Given this list of marker genes Rnf130, Pnisr, Tut4 (terminal uridylyl transferase 4), Rnf150, Tsc22d3, Nop53, Per1, Aph1c, Ssh2, Egr1, Rin2, Gpx1, Pdcd4, Hspa1a, Sult1a1, Il13ra1, Gfra2, Il1b, Brd3, Tent5a, Pold4, Eif3h, Trappc5, Ccdc88a, Sirpb1c, Creg1, Bmyc, Klhl24, Cd48 (CD48 antigen), Il6ra, Stap1, Slc38a9, Stk17b, Dhrs3, Ccl6, Ier2, Fyb1 (FYN binding protein 1), Tnfaip8, Abcc1, Nsa2, Clec4a1, Slc38a1, Nadk, Eef1d, Clec4b1, Npm1, Kctd12 (NCBI Gene Id 239217), Paip2, B4galt6, Slc43a2, Ltb, Mapk14, Rin3 (NCBI Gene Id 97835), Fosb, Rsf1, Klf2, Sla, Ypel3, Macf1, Ing1, Rsrp1, Gdi2, Arhgap9, Dusp1, Ccl9, Ramp1, Jmjd1c, Pmaip1, Cd244a, Niban1, Eef1b2, Prcp, Mcemp1, Tmem50a, Asap1, Dab2, St8sia4, Smpdl3a, Igsf6, Akap13, Hlx, Fth1, Cyp4f16, Ank, Flt3, Cd33, Cnpy2, Nr4a1, Ckb, Clec4a2, Mxd4, Smad7, Arhgap45, Eif3f, Rgs10, Foxp1, Higd2a, Eef2, Cd79b, Mical1, Ndufa6, Mmp12, Gpr183, Mrc1, Parp1, Deptor, Cox7a2l, Tmcc1, Dyrk2, Supt4a, Cd300c2 (NCBI Gene Id 140497), Cd209a, Arl4c, St8sia6, Pid1, Csf1r, Ikbkb, Adam23, Hpgd, Irag2, Sgsh, Fos, Tmem176b, Ifngr1, Ptpn22, Zeb2, B4galnt1, Hfe, Acss1, Cx3cr1, Zfp36l1, Adgre4, Lpin1, Pbxip1, Tmem176a, Adgre1 (adhesion G protein-coupled receptor E1), Sirpa, Clec4a3, Ehd4 (EH-domain containing 4), Cbr3, Bnip3l, Alox5ap, Abca9, Irf4, Klf4, Mef2c, Btg2, Gpi1, Bin2, Stk10, Ppp1r21 (NCBI Gene Id 73825), here is a description of the gene set: studied in species Mus musculus Cytokines mediate cell-cell communication in the immune system and represent important therapeutic targets. A myriad of studies have highlighted their central role in immune function, yet we lack a global view of the cellular responses of each immune cell type to each cytokine. To address this gap, the authors created the Immune Dictionary, a compendium of single-cell transcriptomic profiles of more than 17 immune cell types in response to each of 86 cytokines (>1,400 cytokine-cell type combinations) in mouse lymph nodes in vivo. A cytokine-centric view of the dictionary revealed that most cytokines induce highly cell-type-specific responses. For example, the inflammatory cytokine interleukin-1β induces distinct gene programmes in almost every cell type. A cell-type-centric view of the dictionary identified more than 66 cytokine-driven cellular polarization states across immune cell types, including previously uncharacterized states such as an interleukin-18-induced polyfunctional natural killer cell state. Genes negatively differentially expressed in cell type: cDC2 (conventional dendritic cell type 2) upon treatment with cytokine: IFN-γ in mouse lymph nodes in vivo. Mouse Gene Set: CUI_CDC2_IFNG_RESPONSE_DN from publication Cui A, Huang T, Li S, Ma A, Pérez JL, Sander C, Keskin DB, Wu CJ, Fraenkel E, Hacohen N (PMID 38057668)